Given this list of marker genes ZFP36L1, MYC, GSR, NEDD8, CASP4, S100A4, NME3, CPOX, EIF2B1, ERCC1, DDB2, CDKN1A, TOP2B, GDF15, HDAC3, CAT, XPC, RAD23A, MDM2, here is a description of the gene set: species: Homo sapiens Genes up-regulated in HCT116 cells (colon cancer) after treatment with amifostine depending on the presence of TP53: TP53-positive vs TP53-null cells. The aminothiol WR1065 exerts selective cytoprotective effects in normal cells compared to cancer cells and has clinical applications for the protection of normal cells in cancer patients undergoing radio- or chemotherapy. There is evidence that p53 is activated in response to WR1065. To examine the effects of WR1065 on the signalling pathways controlled by p53, isogeneic human colon carcinoma cell lines (HCT116) differing only in the presence or absence of wild-type p53 were used. Treatment with WR1065 resulted in G1 cell cycle arrest in the p53-positive cell line but not in the p53-negative cell line. Long-term exposure resulted in minimal apoptosis of either cell line. Changes in gene expression in p53-positive or -negative cells treated with WR1065 were examined using commercial human stress and cancer gene arrays (Clontech Atlas arrays). Genes found to be specifically upregulated in a p53-dependent manner included coproporphyrinogen oxidase, ICErel-II cysteine protease, macrophage inhibitory cytokine-1 (also known as placental transforming growth factor beta), S100A4, and Waf1/p21. However, most proapoptotic genes typically upregulated by p53 in response to DNA damage were not activated. These studies show that WR1065 specifically modulates a subset of p53 target genes in a colon carcinoma cell line, consistent with the observation that this agent elicits essentially p53-dependent, cell cycle arrest responses. from publication Mann K, Hainaut P (PMID 15750621) Human Gene Set: MANN_RESPONSE_TO_AMIFOSTINE_UP